Given this list of marker genes Elovl7, Elovl2, Slc27a2, Morc2a, Elovl3, Elovl5, Hacd2, Hsd17b8, Acsl6, Hacd4, Acsl4, Scd1, Hacd1, Hsd17b3, Acsf3, Tecrl, here is a description of the gene set: This event has been computationally inferred from an event that has been demonstrated in another species.<p>The inference is based on the homology mapping from PANTHER. Briefly, reactions for which all involved PhysicalEntities (in input, output and catalyst) have a mapped orthologue/paralogue (for complexes at least 75% of components must have a mapping) are inferred to the other species. Reactome Pathway: Fatty acyl-CoA biosynthesis electronically inferred by orthology from the curated human pathway part of: Fatty acid metabolism studied in species Mus musculus